Given this list of marker genes HOXC13, PAX2, ATP2A2, VIT, AP1G1, EDA, ADAM11, MBNL3, NFIA, TACSTD2, SEZ6, OTX2, CAVIN2, IKZF3, PALS2, RNF128, CHRDL1, SMOC1, TRPS1, MARCKS, RP1L1, CSNK1E (NCBI Gene Id 1454), ARHGAP15, PABPC1, PMM1, IL20, KALRN, GPX1, HOXA11, FAM110D, BAIAP2L2, GRID2, RAPH1, MLLT10, SERPINI2, TMEM154, PAX6, TSC22D3, SLC26A7, SEMA3A, NTNG2, NCALD, MBNL2, CBFA2T2, HNF1A, PRDM12, SREK1, ELMO1, PNPLA6, SSMEM1, PHOX2B, KYNU, LCOR, ETV1, ANKMY2, DIXDC1, SLC20A2, KRT26, HIF3A, TOB1, MEIS2, SIAH3, TMEM35A, POU3F2, TGFBR1, ELK3, CHD2, MAB21L1 (NCBI Gene Id 4081, mab-21 like 1), ZIC4 (NCBI Gene Id 84107), PRMT5, MIA2, IKZF2, SLITRK3, CGN, DSG4, DDX17, RTL9, NPAT, TFEC (transcription factor EC), TMEM87A, IL1RAPL1, VIP, SLC6A5, ARL5B, ATM, HOXC6, SKIDA1, KRTAP11-1, TMSB4XP1, ETV6, SEMA3C, SLC4A4, TBX5, CS, PDE7A, ARRB1, TCF4, FEZF2, UTS2, MAP1B, FOXN3, ATP6V0A1, SLC38A1, MYBPC1, NAALADL2, STAT3, PCDH18, FOXP2, HOXB6, LIG3, CYFIP2, HERPUD2, NKX2-1, IRX4, STMN2, KRT34, RAB6A, ZDHHC12, LINC00303, CXXC5, SLC5A12, PLEKHA6, AUTS2, MTMR12, NEUROD2, RORA, KLF13, ZIC1, HOXD10, SLITRK1, USP32, ZFHX4, PPP1R16A, POGZ, YPEL4, PDZD2, PDZRN4, STARD6, CDAN1, CACNG8, FOXP1, OGG1, C5, MTIF2, BZW2, AFP, MEOX2, MIER3, MAN1C1, WDPCP, CTAGE1, EYA1, TBC1D8B, ITGA11, GPR52, PTPRG, HPN, PPP1R10, PTGFR, GGCX, GABRB2, ARHGAP24, PTPN21, EBF2, SIX3, OTULINL, SND1-IT1, TYRO3, PRDM8 (NCBI Gene Id 56978), MGAT4C, AP1S2, SLC7A9, B2M, ABCB8, SFN, CA4, SEMA5B (semaphorin 5B), SCML4 (Scm polycomb group protein like 4), LRP5, AGAP3 (NCBI Gene Id 83883), HABP2, RFX3, TMPRSS3, DLX1, RHOQ, KCP, CAST, ZMIZ1 (zinc finger MIZ-type containing 1), RALGPS2, RELCH, BEND6, LINC00652, BTBD3, JARID2, HTR2C, GTPBP1, EOMES, CACNA2D3, MTMR6, SOX14, RBFOX1 (NCBI Gene Id 54715), ZMYND8, SOX4, PITPNM2, PLPP3, FAP, GRIA1, HOXC4, RIPK4 (receptor interacting serine/threonine kinase 4), BACE2, ITGA7, TDRD5, CAP1, TECTA, NFIX, LDB2, MYF5, NNAT, PITX2, FGF8, PPP1R14C, ASCL4 (achaete-scute family bHLH transcription factor 4), MSX1, OTUD7B, FOLR1, AQP3, MITF (NCBI Gene Id 7487), LAMB1, DOCK11, SAT1, SYTL2, CPEB4, LRATD2, PLXNA2, SOX5, HAS2, SGCD, ZFP36L2, POU4F3, DCX, PRR34, here is a description of the gene set: Human Gene Set: PAX4_02 species: Homo sapiens Genes having at least one occurrence of the motif NAAWAATTANS in the regions spanning 4 kb centered on their transcription starting sites. This matches the PAX4 transcription factor binding site V$PAX4_02 (v7.4 TRANSFAC).